Given this list of marker genes Rgs9bp, Ppp1r9a (protein phosphatase 1, regulatory subunit 9A), Gxylt1 (NCBI Gene Id 382997), Zfp354c (zinc finger protein 354C), Dnajc28, Plppr4, Dmtf1l, Gria2, Aifm3 (apoptosis-inducing factor, mitochondrion-associated 3), Krtap24-1, Gabarapl1, Eif5a2, Lgalsl, Cbl, Tceal8, Dennd1a, Vstm4, Tpbpa, Tmem47, Naa16, Cdc14a, Ahcyl1, Rnf216, Ggnbp2, Cdkl2, Slc25a16, Cdc27, Klhl5, Ptpn12 (NCBI Gene Id 19248), Nf1, Mycbp, Mro, Hspa4l, Lcor, Lnpep, Gorab, Gucy1a2, Ehbp1, Notum, Mettl21e, Pxylp1, Nckap5 (NCK-associated protein 5), Egf, Ypel1, Ing2, Zdhhc21, Irx3, Serpinb5, Mgarp, Gpr158, Txndc17, Ephb1, Purb, Pnisr, Nckap1, Arg2, Tbc1d8b, Zfp322a, Edil3, Muc15, Tenm3, Uhrf2, Tdo2, Igf2bp1, Scn3a, Hapstr1 (NCBI Gene Id 98045), Svil, Ube2e1, Mef2c, Ktn1, Pls1, Efemp1, Eif2s3x (NCBI Gene Id 26905), Tmprss11g, Nell2, Zfp266, Otc, Dync2h1, Tnks2, Neo1, Me3, Togaram2, Dpp8, Zfp324, Cd164, Galnt7, Csf2ra, Cryl1, Abcb7, Steap2, Prorsd1, Arl8b, Tpk1, here is a description of the gene set: studied in species Mus musculus from publication Chen Y, Wang X (PMID 31504780) Genes predicted to be targets of miRBase v22 microRNA mmu_miR_3964 in miRDB v6.0 with MirTarget v4 prediction scores > 80 (high confidence targets). Mouse Gene Set: MIR_3964